Given this list of marker genes SPRED1, NF1, HRAS, KRAS, NRAS, SPRED2, SPRED3, here is a description of the gene set: RAS signaling downstream of NF1 loss-of-function variants Human Gene Set: REACTOME_RAS_SIGNALING_DOWNSTREAM_OF_NF1_LOSS_OF_FUNCTION_VARIANTS species: Homo sapiens